The following is a description of a gene set: species: Homo sapiens The growth of a cell, where growth contributes to the progression of the cell over time from one condition to another. Human Gene Set: GOBP_DEVELOPMENTAL_CELL_GROWTH, and this is the list of marker genes: NPPA, AKAP6, NPR2, CYFIP1, ANAPC2, SEMA5A, EFNA5, RUFY3, APP, CPNE6, L1CAM, MIR19A, AUTS2, GSK3A, SPART, EPHA7, CLASP2, GSK3B (glycogen synthase kinase 3 beta), MIR199A1, SEMA3G, TRPV2, LIMK1, TMEM108, FN1, PLAA, ARIH2, SORBS2, BARHL2, NRCAM, RTN4R, TWF2, TNR, NRP2 (NCBI Gene Id 8828), PAK6, MIR19B1, PRKG1, RASAL1 (RAS protein activator like 1), ULK2, S100B, TRPC5, EDN3, CYFIP2, TRIM46 (NCBI Gene Id 80128), LLPH (LLP homolog, long-term synaptic facilitation factor), NRN1, SEMA6D, DCLK1, NIN, RGS4, CTDP1, SEMA3F, CPNE1, PI16, SLIT1, SMURF1, SEMA5B, MACF1, FOXP1, ADCY10, TGFBR2, PAFAH1B1, SLC23A2, HDAC6, MIR208A, FGF13, EDN2, PPP3CB, SYT14P1, SEMA7A, EMX1, DSCAM, RAPH1, SLIT2, GDF9, EDNRA (NCBI Gene Id 1909), PTPRS, SPG21, SRF, ADNP, PPARA (peroxisome proliferator activated receptor alpha), NDN, UNC13A, NRN1L, PARP2, RNF6, MEIS1, CDH1, OSTN, MIR195, DNM2, MAP3K13, STK11, GOLGA4, SEMA4F, SEMA6C, SHTN1, CD2AP, MIR24-1, NDEL1, POU4F2, SEMA3A, SLITRK1, NEDD4L, NRP1, EIF2AK4, CTNNB1, BDNF, LAMB2, IMPACT, COL14A1, SYT17, FOXL2, SSNA1, ARHGAP4, NGF, CLSTN3, APOE, FSTL4, MUL1, DRAXIN, DDR1, DCC, RARG, CPNE5, RND2, SOX9, YY1, CDKL3, IST1, SPAG9, FLRT3, GAREM2, RGMA, SMAD7, CRABP2, POU4F3, C9orf72, EDN1, VEGFA, AURKA, RTN4, RIMS2, MEX3C (mex-3 RNA binding family member C), ZFYVE27, MAP2, FLRT1, GATA4, PAK1, CAV3, PLXNA4, WASF1, NLGN3, ATG16L1 (autophagy related 16 like 1), MEGF8, ISLR2, IFRD1, MAPT, VCL, CPNE9, GDI1, ST8SIA2, KMT2D, CTTN, IQGAP1, DCAF13, PDLIM5, ZEB2, MIR199B, PRICKLE1, G6PD, PRKCZ, WNT3A, IGF1, USP9X, KIAA0319, ABL1, MIR23A, COBL, ITGB1, SYT2, SEMA4D, CDH4, PRMT2, SLIT3, POSTN, ITSN2, NTN1, TOMM70, MAP1B, LPAR3, PUM2, SH3GL2, CDK5, TNN, RYK, ITGA4, RAB21, EXT1, PLXNA3, BCL11A, SYT3 (synaptotagmin 3), ALCAM, MAG, CXCL12, SLC9A6, DISC1, WNT3, NTRK3, ULK1, RIMS1, MT3, RGS2, SLC39A12, ADRA1A, BMPR2, NKX6-1, OLFM1, TTL, SPG11, CACNG7, TSC22D4, CDKL5, SIN3A, PLXNA1 (plexin A1), SPP1 (secreted phosphoprotein 1), SYT4, DIP2B, RNF157, WNT5A, DVL1, TNFRSF12A, LHX2 (NCBI Gene Id 9355), PRKN, SYT1, SPAG6